Given this list of marker genes Plscr4, Ano7 (anoctamin 7), Ano6, Ano9 (NCBI Gene Id 71345), Ano4, here is a description of the gene set: studied in species Mus musculus Mouse Gene Set: GOBP_CALCIUM_ACTIVATED_PHOSPHATIDYLSERINE_SCRAMBLING The movement of a population of phosphatidylserine molecules from one leaflet of the plasma membrane bilayer to the opposite leaflet as a result of a calcium stimulus.